Given this list of marker genes CALB2, C1orf210, TFCP2L1, PAQR3, SIKE1, HORMAD1, CHRM3, C21orf91, ELAC1, ITGB8, DSC2 (NCBI Gene Id 1824), LARGE2 (LARGE xylosyl- and glucuronyltransferase 2), ODF2L, PLEKHG4, CDH3, PTEN, FERMT1, CHODL, ANP32E, SPSB1, UGT8, here is a description of the gene set: from publication Landemaine T, Jackson A, Bellahcène A, Rucci N, Sin S, Abad BM, Sierra A, Boudinet A, Guinebretière JM, Ricevuto E, Noguès C, Briffod M, Bièche I, Cherel P, Garcia T, Castronovo V, Teti A, Lidereau R, Driouch K (PMID 18676831) The lungs are a frequent target of metastatic breast cancer cells, but the underlying molecular mechanisms are unclear. All existing data were obtained either using statistical association between gene expression measurements found in primary tumors and clinical outcome, or using experimentally derived signatures from mouse tumor models. Here, we describe a distinct approach that consists of using tissue surgically resected from lung metastatic lesions and comparing their gene expression profiles with those from nonpulmonary sites, all coming from breast cancer patients. We show that the gene expression profiles of organ-specific metastatic lesions can be used to predict lung metastasis in breast cancer. We identified a set of 21 lung metastasis-associated genes. Using a cohort of 72 lymph node-negative breast cancer patients, we developed a 6-gene prognostic classifier that discriminated breast primary cancers with a significantly higher risk of lung metastasis. We then validated the predictive ability of the 6-gene signature in 3 independent cohorts of breast cancers consisting of a total of 721 patients. Finally, we show that the signature improves risk stratification independently of known standard clinical variables and a previously established lung metastasis signature based on an experimental breast cancer metastasis model. Human Gene Set: LANDEMAINE_LUNG_METASTASIS Genes associated with metastasis of breast cancer in the lung compared to the non-lung metastasis. species: Homo sapiens